Given this list of marker genes Tgfb2, Heg1, Gata4, Eng, Sox4, Nog, Bmp2, Tbx20, Gja5 (NCBI Gene Id 70659), Prox1, Bmpr2, Smo, Myh6, Nsd2, Shox2, Sos1, Nkx2-5, Pitx2, Isl1, Notch2, Zfpm1, Cfc1, Ccn1, Ccm2l, Bmp10, Notch1, Wnt2, Tbx5, Acvr1, Mesp1, Tnnt2, Hey2, Dll4, here is a description of the gene set: Mouse Gene Set: GOBP_CARDIAC_ATRIUM_MORPHOGENESIS The process in which the cardiac atrium is generated and organized. A cardiac atrium receives blood from a vein and pumps it to a cardiac ventricle. species: Mus musculus